Given this list of marker genes ZFP41, CBX1, SETDB2, PHF13, ANKRA2, SERF1A, USP48, TEDC1, MPV17L2, POT1, MKRN2, RUFY3 (RUN and FYVE domain containing 3), C9orf78, LIN52, LRRC1, NUP50-DT, FLT3, PLPP6, MAP3K13, TRADD, APBA3, TTI2, KCTD9, HENMT1, KLHDC2, YARS2, H2BC4, NCBP3, RASSF1, DEPP1, GRSF1, PKNOX1, NUB1, MTMR4, NELFA, JPT2, MTG1, LGALS3BP (galectin 3 binding protein), RNASEH2B, ANXA3, RSAD1, POLR2D, C9orf72, KDM2A, TRAF5, MED7, SS18, ABHD15, NPIPA1, TPST1, TFCP2, SMAP2, PAQR3, MARCKSL1, CIP2A, REPIN1, ZSCAN16 (NCBI Gene Id 80345), LMBR1L, MBOAT2, ZNHIT3, MOB1A, EPM2A, DNAJC9 (NCBI Gene Id 23234), FAM222B, GABPB1, ORC3, N4BP2L1, MRPS28, H2AX, PIGC, PTGR3, LAD1, BTN3A1, ANO7L1, RBM34, B4GALT7, TBC1D22B, RRP36, EOLA1, ATG14, TTPAL, CTC1, AP3S2, SNUPN, UBE2R2, RETREG3, BUB3, GTDC1, MRPL46, NUP37, H2AC18, ZNF33B, TMEM41A, SIMC1, CELF2, ZNF630, MTFR2 (NCBI Gene Id 113115), MOB1B, JADE3, EPDR1, SERPING1, ZBED10P, PXYLP1, DIPK1A (NCBI Gene Id 388650), ROCK2, MRPL44, NFATC2IP, AGFG2, MOAP1, TRMT112, ZNF22, KAT6B (NCBI Gene Id 23522), SNAPC3, THAP11 (THAP domain containing 11), SUGT1, AASDHPPT, PIAS3, ADTRP, SCAMP1-AS1, GID4, PTCD1, RALGAPA2, ZMYND19, TMEM187, KDM4A, LRRC47, PHLPP2 (NCBI Gene Id 23035), SLC25A36, HCP5, COMMD2, PHKB, SNAP47, RAB23, H2BC6, ZNF844, NFIL3, FLVCR1, TMCC3, NSUN5, MACIR, RCOR3, LHFPL2, FBXW2, CYP27B1, HSD17B7, CSTF2, CCDC77, NIT2, DDX28, C12orf76, RNPS1, PIAS1, LDHC, WRAP53, BTN3A2, RPA2, ZC3HC1, PML, LYST, PDRG1, SUPT16H, FERMT2, CIAO3, PDS5B, H3C10, ZDHHC13, PEF1, TMEM185A, GGH, EOLA2, ZNF142, C2CD3, RPAP3, BSDC1, TMEM184C, HSH2D, PABPN1, KLF5, NXT1, SLC38A5 (solute carrier family 38 member 5), HEXD, FSTL1, GLT8D1 (NCBI Gene Id 91870), IFITM2, MRPL45, DHX16, CDK9, CCDC137, STAG3, FEN1, SCO1, CSF2RA, NAXD, GPKOW, NCOA6, TMEM199, POLRMT, ENTHD1, GPN2 (NCBI Gene Id 54707), here is a description of the gene set: species: Homo sapiens Genes down-regulated in comparison of dendritic cells (DC) at 4 h after LPS (TLR4 agonist) stimulation versus those at 16 h after the stimulation. Dendritic cells (DCs) are the sentinels of the mammalian immune system and they undergo a complex maturation process mediated by activation upon pathogen detection. Recent studies described the analysis of activated DCs by transcriptional profiling, but translation regulation was never taken in account. Therefore, the nature of the mRNAs being translated at various stages of DC activation was determined with the help of translational profiling, which is the sucrose gradient fractionation of polysomal-bound mRNAs combined to microarrays analysis. Total and polysomal-bound mRNA populations were compared in immature (0h) and LPS-stimulated (4h and 16h) human monocyte-derived DCs with the help of Affymetrix microarrays. Biostatistical analysis indicated that 296 mRNA molecules are translationally regulated during DC-activation. The most abundant biological process among the regulated mRNAs was protein biosynthesis, indicating the existence of a negative feedback loop regulating translation. Interestingly, a cluster of 17 ribosomal proteins were part of the regulated mRNAs, indicating that translation may be fine-tuned by particular components of the translational machinery. Our observations highlight the importance of translation regulation during the immune response, and may favour the identification of novel gene clusters or protein networks relevant for immunity. Our study also provides information on the possible absence of correlation between gene expression and real protein production in DCs. Human Gene Set: GSE14000_4H_VS_16H_LPS_DC_DN from publication Ceppi M, Clavarino G, Gatti E, Schmidt EK, de Gassart A, Blankenship D, Ogola G, Banchereau J, Chaussabel D, Pierre P (PMID 19943945)